The following is a description of a gene set: Slightly elevated lesions on or in the skin with a diameter of over 5 mm. studied in species Homo sapiens Human Gene Set: HP_SUBCUTANEOUS_NODULE Subcutaneous nodule, and this is the list of marker genes: APOE, SEC23B, AKT1, MYCN (MYCN proto-oncogene, bHLH transcription factor), COL5A2, APC, LEMD3, LSS, COL7A1, B2M, SDHD, KLRC4, PORCN, FGFR2, UBAC2, SDHB, ANTXR2, ABCC6, IL23R, FAS, HLA-DRB1, ALK, LMO1, TSC1, TNFRSF11A, CYLD, FUS, INSR, IDH1, TLR4, COL1A1 (collagen type I alpha 1 chain), NAGA, IFNG, DDIT3, KRAS, ENPP1, GLA, ZEB2, PDGFRB, SDHC, KLLN (NCBI Gene Id 100144748), IL12A, SALL1, IARS2, LIN28B, COL5A1, TSC2, IDH2, CCR1, IFNGR1, COL3A1, PHOX2B, POMP, ASAH1, MEFV, MMP14, PTEN (NCBI Gene Id 8037), PDGFB, STAT4, FERMT3, PIK3CA, DACT1, SOX5, MMP2, OCRL, GNAS, ECM1, ERAP1 (endoplasmic reticulum aminopeptidase 1), RAF1, NOTCH3, BTNL2, HMGA2, MDM2, USF3, HLA-B, KIF11, IL12A-AS1, FGFR1, ACVR1 (activin A receptor type 1), TEK, BRAF, FBN1, GLS, MYSM1, CDK4, IL10, PTH1R, PTPN11 (protein tyrosine phosphatase non-receptor type 11), HACE1, C4A, NRAS, CTNNB1, TNFRSF11B